The following is a description of a gene set: Reactome Pathway: Interleukin-21 signaling species: Homo sapiens part of: Interleukin-2 family signaling Interleukin-21 (IL21) is a pleiotropic cytokine with four alpha-helical bundles. It is produced primarily by natural killer T cells, T follicular helper cells and TH17 cells, with lower levels of production by numerous other populations of lymphohaematopoietic cells (Spolski & Leonard 2014). IL21 binds Interleukin-21 receptor (IL21R, NILR) and Cytokine receptor common subunit gamma (IL2RG, GammaC).<br>IL21R has significant homology with the class I cytokine receptors Interleukin-2 receptor subunit beta (IL2RB) and Interleukin-4 receptor subunit alpha (IL4R) and was predicted to similarly form a complex with IL2RG. IL21R dimers can weakly bind and signal in response to IL21 but IL21 generates a much stronger response when IL21R is combined with IL2RG, which is required for a fully signaling capable IL21 receptor complex. IL21R can bind Janus kinase 1 (JAK1) but IL2RG is required for IL21 induced signaling. The heteromeric IL21 receptor complex can activate JAK1, JAK3, Signal transducer and activator of transcription 1 (STAT1), STAT3, STAT4 and STAT5, depending on the cell type. In cultured T-cells IL21 induced phosphorylation of JAK1, JAK3, STAT1, STAT3 and weakly STAT5. In primary CD4+ T cells IL21 induced the phosphorylation of STAT1 and STAT3 but not STAT5, whereas IL2 induced the phosphorylation of STAT5 and STAT1 but not STA3. IL21 stimulation of primary splenic B cells and the pro-B-cell line Ba-F3 induced the activation of JAK1, JAK3 and STAT5. In primary human NK cells or the NK cell line NK-92, IL21 induced the activation of STAT1, STAT3, and STAT4 but not STAT5. IL21 activated STAT1 and STAT3 in human monocyte-derived macrophages (Vallières & Girard 2017)., and this is the list of marker genes: IL2RG, STAT3, IL21R, JAK3, STAT4, IL21, JAK1, STAT5A, STAT5B, STAT1